The following is a description of a gene set: from publication Chen Y, Wang X (PMID 31504780) species: Homo sapiens Human Gene Set: MIR6787_3P Genes predicted to be targets of miRBase v22 microRNA hsa-miR-6787-3p in miRDB v6.0 with MirTarget v4 prediction scores > 80 (high confidence targets)., and this is the list of marker genes: VPS50, LRRC4, RMDN3, TPBG, SOX2, TAF5L, GTF2E1, PATZ1, ZNF250, PITPNM3, SRP54, SEC22C, PHACTR2, GRAP2, ITGA10, TIMP3, SLC31A1, PELI2, PLP1, TEX12, SVBP, TBC1D15, MIEF1, RNF138, ST7, EFTUD2, CLDN12, MRAP2, WNT9B, ODF2, TRPM3, GZMB, NCOA4, ADAMTS6, CFH, CFHR1, CASP7, MOSPD2 (NCBI Gene Id 158747), BCL11B, FGFR3, SRPK2, KDM4A, CNTNAP2, SEPTIN8, MIPOL1, THSD7B, KIF1B, DOK6, NUP133, MOB1B, ETS1, LYRM7, CTNNB1, OGA, NYNRIN, ASB6, KCNQ2, RBMS1, SLC35A2, ZNF831, INAVA, SNAP25, SNRPF, SPAG9, TUB, PID1, RAB5B, NBEA, MDM4, YBX2, HOMER1, FBXO11, MOB4, SEMA4G, ANKRD40, AQP4, PRR14, HSPE1-MOB4, ZIC4, ATRX, YTHDF2, CAMK2G, EIF4E2, FMN1, RANBP9 (RAN binding protein 9), ARMC8, SYDE2 (synapse defective Rho GTPase homolog 2), FBXL5, TFDP2, RAB8A, TAF12, EBI3, CFHR5 (complement factor H related 5), RHOT1, SLC6A7, OSTC, EEIG2, PEX13, MKLN1, SNN, DIDO1, SF3A3